The following is a description of a gene set: Human Gene Set: MODULE_204 species: Homo sapiens Genes in the cancer module 204., and this is the list of marker genes: GRIN1, PSMD13, RNASEH2A, LMNB1, LDB2, GBP1, FEN1, TFAP2A, POU2AF1, MCM3, TCL1A, ZNF263, CCL19, GART, SERPINA3, CARTPT, PTPRCAP, MYO1A, GMDS, TEK, MPG, PUM3, NDEL1, CPVL, ATP2A3, EZH2, FCN1, SOCS2, CEL, GORASP1, DOP1B, AGT, HRAS, RRM1, PCNA, SCML2, UGT1A4, FXYD3, DDX17, TM7SF2, AUTS2, H2BC5, POLR1C, CHI3L1, PQBP1, ANAPC15, RSBN1, PGAP2, FOXM1 (forkhead box M1), CRIM1, BBC3 (BCL2 binding component 3), COG5, RAMP2, MSH2, MLLT11, CXCL10, CAND1, DDX23, CD27, HCK, TMEM8B (transmembrane protein 8B), AHDC1, PTK7, S100A9, TPX2, HLA-DQA1, TRPC4AP (transient receptor potential cation channel subfamily C member 4 associated protein), PRPF6 (pre-mRNA processing factor 6), HSPA6, SPIB, SF1, NUP210, CRMP1, ABCC5, TRIM22, NUP58, CHKB, CCS, CHPF, LILRB3, SV2A, ICA1, CD24, STK39, CSRP2, BLNK